Given this list of marker genes NOS3, DNM2, CAV1, WASL, NOSTRIN, here is a description of the gene set: Human Gene Set: REACTOME_NOSTRIN_MEDIATED_ENOS_TRAFFICKING NOSTRIN mediated eNOS trafficking species: Homo sapiens